The following is a description of a gene set: Generalized lymphadenopathy A generalized form of lymphadenopathy. species: Homo sapiens Human Gene Set: HP_GENERALIZED_LYMPHADENOPATHY, and this is the list of marker genes: IFIH1, PRKCD, HLA-DRB1, NFATC2, DCLRE1C, RNF168, TNFRSF9, LRBA, RAC2, IFNGR1